Given this list of marker genes FGF7, FGF20, FGF9, FGF18, FGF22, FGF8, FGFR2 (fibroblast growth factor receptor 2), FGF23, FGF10, FGF2, FGF1, FGFBP2, FGF4, FGF5, FGFBP3, FGF16, FGF17, FGF3, FGF6, FGFBP1, here is a description of the gene set: Dominant mutations in the fibroblast growth factor receptor 2 (FGFR2) gene have been identified as causes of four phenotypically distinct craniosynostosis syndromes, including Crouzon, Jackson- Weiss, Pfeiffer, and Apert syndromes. FGFR2 binds a number of different FGFs preferentially, as illustrated in this pathway.<br><br>FGFR is probably activated by NCAM very differently from the way by which it is activated by FGFs, reflecting the different conditions for NCAM-FGFR and FGF-FGFR interactions. The affinity of FGF for FGFR is approximately 10e6 times higher than that of NCAM for FGFR. Moreover, in the brain NCAM is constantly present on the cell surface at a much higher (micromolar) concentration than FGFs, which only appear transiently in the extracellular environment in the nanomolar range. part of: Signaling by FGFR2 studied in species Homo sapiens Reactome Pathway: FGFR2 ligand binding and activation